Given this list of marker genes SLC26A6, SLC5A3, AQP3, AQP9, AQP2, AQP1, AQP11, AQP7, SLC5A11, AQP7B, AQP10, here is a description of the gene set: Human Gene Set: GOBP_POLYOL_TRANSMEMBRANE_TRANSPORT The directed movement of polyols, any polyhydric alcohol, across a membrane. species: Homo sapiens